The following is a description of a gene set: Human Gene Set: ZNF579_TARGET_GENES species: Homo sapiens Genes containing one or more binding sites for (ZNF579) in their promoter regions (TSS -1000,+100 bp) as identified by GTRD version 20.06 ChIP-seq harmonization. from publication Yevshin I, Sharipov R, Kolmykov S, Kondrakhin Y, Kolpakov F (PMID 30445619), and this is the list of marker genes: FZD1, IQCE, PMS2, ICMT, ATP6AP1L, SNHG19, DNAAF4-CCPG1, HSP90AB1, MRPS9-AS2, PPIA, RNA5SP18, UPP2, ANKRD11, DPP9, SLC14A2, FAM201B, UGGT2, ABCA2, SCAPER, KIAA0825, LINC01716, SCN8A, LINC01600, CASTOR3P, AIMP2, CDK11A, VPS51, RPL28, CDHR3 (NCBI Gene Id 222256), ECHDC2, PRKCI, ZNF146, PIH1D1, PPP1R37, WBP11, KCNK1, HDGF, RBM4B, CCT8, IGSF9, ATXN7L1, ZNF815P, FHIP1A-DT, CNPY4, PDE6D, CLK3, LRRC37A6P, PAIP2B (poly(A) binding protein interacting protein 2B), MNT, MRPL54, HDDC2, KLF4, ZNF581, RN7SL3, CCDC117, RPL18, LRRC37A5P, MAPKAPK5-AS1, FZD4, ARHGAP4, TNIK, RPL29, ANKLE2, MVB12A, NLGN2, HCG18, SPSB1, ISY1, MIR200CHG, FOXN2, DEF6, FZD4-DT, TMEM161B-DT, GYG1, UBE4A (ubiquitination factor E4A), SEC14L5, PGAP1, SUGT1P4-STRA6LP, MMP11, FOXD1, MIPEPP3, AAK1, VASP, ZBTB3, CNEP1R1, BRD4, SMG7-AS1, TRAPPC8, RPL7A, TYW5, ATP13A1, NDUFA10, SUGT1P4-STRA6LP-CCDC180, TMEM44, GSE1, STXBP5L, RRAGC, METAP1, UNC13D, COPS7B, PBX2, ANKEF1, TCF3, ARL2BP, IL1RAP, PIGS, CHD1, ZNF517, TNNC2, TMEM219, SETDB2, INTS6L, AFTPH-DT, ILVBL, IER3, TMEM256, ABL2, LINC01276, CAB39L, EML5, SLC25A34, CORO2A, TRIM41, ERCC1, C7orf25, HES5, CNKSR1, GET3, RORA-AS1, RAB3D, ZNF670-ZNF695, PPP1R3E, F2, AVL9 (NCBI Gene Id 23080), AK4, COX6A1, CLBA1, KLHL13, TBC1D31, MMP15, TEP1, AAAS, CLPB, LYPD3, GALNT10, FZD5, SDCCAG8, DLG1, CDCA4, ZNF34, RAC1, FAM118A, PLEKHG2, CCNY-AS1, ENSG00000237813, ACY1, ABHD3, CCN5, JAGN1, BLTP2, SNHG31, SPOPL, RIN1, AKAP10, ADNP, LRRC37B, CD2BP2, ADRB3, BACE1, RAB23, UBA2, ZNF749 (zinc finger protein 749), RGS9, CRELD1, BCAS4, BLVRA, NDUFB10, ADI1, ARSD, FBXO30, TFG (NCBI Gene Id 50989), RPL23AP53, ZNF670, SPECC1L-ADORA2A, GPR160, SLC30A6, KCNQ2, TMEM242-DT, FYTTD1, CIRBP, DCP1A, RPL12P41 (ribosomal protein L12 pseudogene 41), RSAD1, HLA-E, PLEKHB1, CYREN, LNPEP (leucyl and cystinyl aminopeptidase), SLC16A3, RASA4CP, NT5DC3, NDUFS7, VPS37D (VPS37D subunit of ESCRT-I), CBX1 (NCBI Gene Id 10951), POLR2G, POLD3, GPRC5B (G protein-coupled receptor class C group 5 member B), SLC38A1, GDPGP1, VGLL4, TSFM, RPS10P29, NIPA1, RUNDC3B, MBNL3, RPL39P5, TMEM238, DLG1-AS1, BANF1, FAM83A, FBXO31, TSPOAP1-AS1, ZNF497, ARNT2, ICMT-DT, UNKL, VPS26C, IGSF9B, MECOM, GAB1, COPS5 (NCBI Gene Id 10987), MEX3C, RYBP, ITGB2, SRCIN1, ANKRD2, GGCTP1, INTS7, UGCG, H3P23, VPS11, CEP63, HPS6, RAB25, RASSF8-AS1 (NCBI Gene Id 100509094), FAM133B, ZNF18, CHCHD10, ACSF2, COPB2, STK10, STK3, BRI3, MIR9-1HG, GAN, ZNF846 (zinc finger protein 846), MAPKAPK5, RNU6-826P, RPA1, PHKB, MOCS2-DT, KIAA1671, ZNF596, KCTD18, NECTIN4-AS1, PATL1, ARNT2-DT (NCBI Gene Id 101929560), FXYD5, LINC03052, MTBP, GINS3, PUS7L, ANKRD13A (NCBI Gene Id 88455), EARS2, RAB6A, CGGBP1, HUS1, GPD1L, CLPTM1, BCL11B, EFNA5, CDK2AP2, LINC00957, ZNF800, STX16, SDHAP1, MBNL1, TUBA1C, AADAT (NCBI Gene Id 51166), RASAL2-AS1, NICN1, RAP2A, ZKSCAN1, FNTB, EPOR, ZNF233, TUBGCP2, LPCAT4, TATDN1, DYNLL1, PDE11A, HDAC5, TTC32, SAMD4B, RIOX1, RPL24, ZNF799, JARID2-DT, MEIOC, OVOL1, MLYCD, STX16-NPEPL1, ZFAND2B, NBPF12, ANXA3, HSD17B7, PPIL3, LUZP1, UPF2, HM13, CLP1, BISPR, CUTC, MIB1, SYBU, GNPTAB, KCNAB1, SPRY4 (NCBI Gene Id 81848), TRIM44, CABIN1 (NCBI Gene Id 26293), NPRL3, PRPF18, RANBP2, ACLY, MFSD9, C17orf75, CTPS2, FUT11, ANKRD19P, WNT2B, PLRG1, RPL26, DYNC2I1, ADGRV1, BTG2, HMGN4, CEP170, HDAC6, SPECC1L, MFAP3L (microfibril associated protein 3 like), GALNT6, LIX1L-AS1, TEAD1, DNAJB1, SGSM1, TRA2A, RAB3IL1, KDM4B, PTPRF, ENSG00000255326, CCNB1, INTS13, WWP2, RN7SL525P, IGHV1-3, NPHP3, TMEM182, UNC93B1, SPART, TRIM39, HIP1R, NAA10, APBA3, ZNF488, BRAP, GRB14, SPRY4-AS1 (SPRY4 antisense RNA 1), PLEKHA6, SLC11A2, CHRNE, SNX21, TRIM28, KIF22, ARNT, FGD3, MACROH2A1, COMMD2, BBC3, PSMG2, MARK2, TNPO2, TRIM7, MRPL45, LINC03047 (NCBI Gene Id 107986898), ECSIT, FEM1A, SLC9A7, SEC1P, ICE2, CHASERR, APEX2, FCHSD2, YKT6, SUN1, ABR, TMEM161B, ZBED5, RARG, MIR9-2HG, CT66 (cancer/testis associated transcript 66), ZNF566, ZNF213-AS1, HMCN1, PDF, TAF6 (NCBI Gene Id 6878), WDR38, LMBR1, SLF1, DNMT3A, PGPEP1, ELN-AS1, CMTM4, NDFIP1, C3orf38, SLC10A3, DLX1, PLIN3, YEATS2, SLC12A4, ZNF181, COMT, TMEM205, LMTK3, JARID2, NUP43, PDE5A, APOO, MED15, PCBP1-AS1, CCDC183-AS1, ILF2, TTC36-AS1, TBC1D1, KANK2, APBB2, HIF1A, BCKDK, SHFL, TMEM256-PLSCR3, RPS7, FLT3LG, DLST, HSPA12A, LINC01778, NADK, PCF11, LRAT, GLI1, NARS1, RRAGC-DT, SAMD11, NEDD1, GNPNAT1, TBCD, TERF2, CCT4, MAP1LC3B, EXTL3, KRT87P, GNA13, GXYLT1, CSNK1G3, FRMD3-AS1, NME6, BAX, EAF2, SETD7, RCC1L, RFX2, LYSMD3, TTC14, SAR1A, ISLR2, ANKZF1, ISY1-RAB43, DBP, ADRM1, CDV3, STAT6, CAV2, UGP2 (UDP-glucose pyrophosphorylase 2), HTR5A, DAGLB, RAB19, ELOVL5, ESR2, CCDC66, GRN, ASB13, PDCL3, AP1G1, TH, NAXE, VTN, CDC123, KLHDC2, LINC00240, CCDC74A, CD2BP2-DT, PCBP1, ZNF511, SRI, LSM5, MXI1, UIMC1, SPOPL-DT, MMP25, FAM220A, LAD1, SNAP25-AS1, TMEM191B, SUGT1P4, MAIP1, CLTB, HOOK2, BTG2-DT, TACR2, COMMD10, CCDC74B, ARHGEF38, MYO1C, VPS16, PITPNM1 (NCBI Gene Id 9600), CROCCP3, ARHGAP5, TATDN2, SLC39A3, CEND1, ZNF641, CDH13-AS2, ARHGAP27P2, ZNF566-AS1, EBF4, PPP2R2A, ZNF579, EYA3, VAT1, CEBPG, TMEM25, USP48, NDUFB9, SEC22A, FLVCR1, ZNF112, ZNF136, SLC9A6, KAZALD1, ACVR1, PDE7A-DT, NUDT5, LINC02352, PIP5KL1, NCK1, PTPRA, BARD1, NMNAT3, RAB40C, WDR43, MTTP, IPPK, ANGPTL6, MAP7D1, LINC00910, TCIRG1, STXBP3, NR2F2 (NCBI Gene Id 7026), ESRRB, TIGD2, ABCC13, SERAC1, CELF1, BRMS1L, RPL11, UBA52, XKR8, BST2, RPS4X, EXOSC3, ZNF521, LPCAT1, SH3GL3, PRSS8, PEX14, RNF24, DNPEP, KGD4, DEF8, VEPH1, CSPP1, TMEM242, PRUNE2, MEF2A, H4C5, LINC01767, RASA3, KLK6, TTC14-DT, FKBPL, XK, C1QBP, PPP4R3A, RBBP6, PPP1R9B, BCRP2, ANXA4, SMYD4, RBM8A, RHOB, VAMP4, RNU4-41P, DTX4, NRDE2, MOGS, SPHK2, KBTBD11, SMARCD2, KICS2 (NCBI Gene Id 144577), MOSPD3, LIPT2-AS1, NOSIP, CREB5, ZNF511-PRAP1 (ZNF511-PRAP1 readthrough), TPRN, TSC22D2, TBL2, SLCO3A1, SLC38A2, SLC41A2, ZNF443, FHIP1A, COX5A, DAZAP1, ZNF562, FAAP20, PTOV1, MRI1, CDK5RAP1, BCYRN1, LINC02324, PKD1L2 (NCBI Gene Id 283928), PTOV1-AS1, CTNND2, CCDC159, NEMF, SVOP, MRPL13, CYP1B1, RGS3, MICAL3, PLCG2, PMS2CL, CDKL4, B4GALT7, AARS2, SEPHS1, SMG7, ITGAL, SSBP1, SMTN, RPN1, GDPD2, SOX13 (NCBI Gene Id 9580), CNTD1 (cyclin N-terminal domain containing 1), PPIE, PRRT3, CCNG1, DNAAF4, TMEM191A, TDRD7 (tudor domain containing 7), PATL1-DT, NBPF19, CDK20, LINC02747, WIPI2, PDE7A, EIF1AD (eukaryotic translation initiation factor 1A domain containing), ZFAND1, CDYL-AS1, MPO, DHRS4-AS1, ZBED5-AS1, TMEM39A, ARPC5L, IRF6, VARS1, EIF4A2, SLC7A8, AGRN, TTC32-DT, MARS1, VAT1L, BLTP3B-DT, XPC, PNPLA6, RNF138, RHPN2, FOXN3, DNAH11, MAP4, DNAJC25, KCTD3, DBR1, HOOK1, RPL5P28, ASPHD1, NHSL3, RPS23, VPS11-DT (VPS11 divergent transcript), POLR2D, HOXA11-AS, DNAJC25-GNG10, PIK3R1, OSBPL8, FUT10, IL17RC, LFNG, TKT, CALM2, WDR36, RUBCN, TJP3, NDRG3, GABARAPL1, FAM178B, CYP1B1-AS1, FAM199X (NCBI Gene Id 139231), NPHP3-ACAD11, COX15, ARF1, CCN1, SLC35E2A, RNF220, UBE2Q2, NXPH3, IRX3, REEP1, TRAPPC12, SRSF9, COA3, AFTPH, ADAMTS6, TRMT1, IL4R, TP53INP2, SLC35B1 (NCBI Gene Id 10237), RNA5SP473, RRP1, TMEM42, UBFD1, DOC2A, ATG9A, MIR635, ZBTB24, MIR200C, CTDSP1, ZNF497-AS1 (NCBI Gene Id 105372483), ITGA3, INTS6L-AS1, MOCS2, POU2F3 (NCBI Gene Id 25833), AIFM1, TMEM164, TWF2, ENSG00000267024, LIPT2, HOXD1, MRPL45P2, RPL39L, EPM2A-DT, ZNF213, PHF21A, BZW1 (basic leucine zipper and W2 domains 1), IZUMO4, WEE2-AS1, COPS4, ZNF770, ARAP1, TTC4, ZNF341, UBE2I, GALNT9, RN7SL774P, RBBP5, LDLRAP1, SERHL, DUSP6, PAPOLA, FAAHP1